Given this list of marker genes Wnt5a, Phb2, Tgfb1, Etv5, Cav3, here is a description of the gene set: Mouse Gene Set: GOBP_REGULATION_OF_BRANCHING_INVOLVED_IN_MAMMARY_GLAND_DUCT_MORPHOGENESIS species: Mus musculus Any process that modulates the rate, frequency, or extent of branching involved in mammary gland duct morphogenesis.